The following is a description of a gene set: Divergence of the longitudinal axis of the hand at the wrist in a posterior (ulnar) direction (i.e., towards the little finger). Ulnar deviation of the hand Human Gene Set: HP_ULNAR_DEVIATION_OF_THE_HAND species: Homo sapiens, and this is the list of marker genes: MUSK, PIK3CA, PCDHGC4, MAP3K7, SPART, MYH3, B9D2, ADGRG6, LBR, COL9A1, ALG9, COL9A3, PAX3, ASXL3, PEX1, ZEB2, RBM8A, COMP, COL9A2, RBM28, MAFB, LAMA5, MAN2C1, RYR3, FLNA, CILK1, BICD2, MED12, SLC26A2, FAT4, DPYSL5, ERI1, FRA10AC1